The following is a description of a gene set: Any process that activates or increases the frequency, rate or extent of programmed cell death, cell death resulting from activation of endogenous cellular processes. Mouse Gene Set: GOBP_POSITIVE_REGULATION_OF_PROGRAMMED_CELL_DEATH species: Mus musculus, and this is the list of marker genes: Cd40lg, Casp4, Uaca (uveal autoantigen with coiled-coil domains and ankyrin repeats), Fas, Cxcr2, Apbb2, Rbm10, Bmyc, Siah1b, Tnfrsf1a, Htra2, Sirt2, Rrp1b, Tnfrsf10b, Tpd52l1, Bace1, Tcf7l2, Ube2m, Itpr1, Pdcd5 (NCBI Gene Id 98188), Alox12, Nfatc4 (NCBI Gene Id 73181), Nr4a3, Oga, Gadd45g, Tnfsf11, Itm2c, Syk, Nlrc4, Calhm2, Ctsc, Grp, Stk17b (NCBI Gene Id 98267, serine/threonine kinase 17b (apoptosis-inducing)), Fank1, Srpx, Cflar, Ptgis, Camk2b, Camk2d, Pdcd5-ps (NCBI Gene Id 100046198), Cyld, Zfp622, Fbxw7, Prelid1, Bmf, Hrk, P2rx7, Nos3, Mmp9, G0s2, B4galt1, Pin1rt1, Ccn2, Trem1, Endog, Runx3, Adamtsl4, Trpv1, Tex261, Casp7, Zfp346, Nsmaf, Ei24, Gsk3b, Inca1, Ptpa, Jak3 (Janus kinase 3), Septin4, Pak2, Adcy10, Selplg, Fap, Rpl26, Jmy, Fis1, Casp12, Casp8, Fadd, Pawr, Rbm5, Pias4, Rps6-ps4 (NCBI Gene Id 672620), Gper1, Ptgs2, Tsc22d1, Casp9, Bin1, Taf6, Pdcd1, Mmp2, Lpar1, Tfap2b, Trp63, Cdc42, Lats1, Laptm5, D1Pas1, Sod1, Nck1, Neurl1a, Fzd9 (NCBI Gene Id 14371), Bcl2, Tnfsf10, Arg1, Ctla4, Sap18, Map3k11, Itga4, Ptpn1, Ecscr, Bnip3l-ps, Unc13b, H2-M3, Slc27a4, Kcnma1, Plagl2, Map2k4, Ldha, Spink2, Acvr1c, Cdkn2a, Cdk5, Prmt2, Hcar2, Pdcd4, Ahr, Col18a1, Pak3, Grik2, Map3k10, Nos2, Adipoq, Gch1, Il10, Ppp2r1b, Scin, Hmgcr, Ccl12, Grin2a, Inhbb, Rps7, Phb1, Phlda2, Melk, Egr1, Pla2g4a, S100a8, Emilin2, Rapgef2, Bad, Hspa9, Neurod1, Bcl2a1a, Plcg1, Pik3cb, Ctnna1, Nkx3-1, Pomc, Lta, Ndufa13, Slk, Oma1 (NCBI Gene Id 67013), Stpg1, Skil, Ncoa1, Tnfrsf8, Nacc2, Mfn2, Scp2, Ddx3x, Perp, Mtch1 (NCBI Gene Id 98058), Cyct, Foxo3, Ptrh2, Hrg, Itga6, Atf6, Grik5, Apaf1, Ddit3, Fnip1, Casp3, Rps3, Zc3h12a, Foxa1, Epha7, Lcn2, Ptprc, Nox4, Ccl3, Sfpq, Bcap31, Rarb, Arrb1, Agtr2, Dkkl1, Nqo2, Unc5b, Prkci, Cradd, Chek2 (NCBI Gene Id 50883), Ppp1r15a, Folh1, Itga1, Ppargc1a, Bcl2l10, Stat1, Mybl2, Pmaip1, Htatip2, Vdr, Cnr1, Ntrk1, Pdcd2, Aldh1a2, Sox4, Nf1, Cryba1, Gadd45a, Cd160, Tmem164, Psen2, Apc, Tspo, Cers6, Traf2, Socs1, Aimp2, Dnaja3, Wnt10b, Bcl2a1d, Wnt11, Grk2, Sp110, Atg7, Akt1, Trp53bp2, Ing4 (inhibitor of growth family, member 4), Tctn3, Eif5a, Cxcr3, Pml, Mal, Tgfbr1, Ptprf, Ifnb1, Eef1a2, Mybbp1a, E2f3, Trpm7, Olfm1, Sfrp4, Tia1, Tnfrsf22, Gpld1, Pdcd7, Cav1, Cck, Nupr1, Il18, Bcl2a1c, Il19, Ace, Daxx, Jak2, Htra1, Ntrk3 (NCBI Gene Id 414121), Fasl, Tnfsf14, Sap18b, Trim39, Creb1, Muc20 (mucin 20), Muc2, Ing5, Tnfsf15, Nod1, Degs1, Gramd4, Ect2, Tbx20, Tgfb3, Gsn, Capn1, Bdnf, Bbc3, Spdef, Bclaf1, Sphk2, Styxl1, Gsk3a, Ubb, Msx1 (NCBI Gene Id 269644), Steap3, Tradd, Ripk2, Atf2, Prdm11, Clip3, Adrb1, S100a9, Sirt1, Brms1, Diablo, F2r, Bcl2l11, Rarg (retinoic acid receptor, gamma), Spry1, Pparg, Ep300, Nfatc3, Lzts2, Aifm1, Fto, Dffa, Emilin1, Hdac4, Musk, Dlc1, Tgfb2, Tnfsf12, Prr7, Htt, Nox1, Adm, Ido1, Rad9a, Usp27x, Bcl10, Csrnp3, Map3k1, Myb, Parp1, Ppp1ca, Dnm1l, Lrp6, Esr2, Ptpn2, Arrb2, Dhodh, Srpk2, Map2k6, Plekhn1, St8sia2, Clu, Ngfr, Cdk4, Bak1, Rbck1, Ager, Pitx3, Cd47, Vdac1, Nck2, Ncf2, Lep, Tlr3, Msx2, Fam162a, Park7, Nqo1, Ltbr, Rybp, Prkn, Faf1, Aifm2, Ppp2r2b, Tlr4, Bag1, Prkcd, Pou4f1, Fcer2a, Lyn, Rnf122, Txnrd1, Men1, Hmgb1 (NCBI Gene Id 15289), Tle5, Txnip, Phlda3, Mtch2, Utp11, Lgals1, Slc9a1, Siglec1, Foxl2, Cdc34b, Ctrb1, Notch2, Ptn, Zbtb16, Dapk3, Anxa1, Zbp1, Zfas1, Efhc1, Trp73, Rps6ka2, Nfkbid, Dapk1, Bmp4, Fbxo32, Bnip3, Rps6, Fbh1, Grn, Carm1, Moap1, Atf3, Tlr6 (toll-like receptor 6), Rhob, Ankrd1, Dcun1d3, Zmat3, Myc, Agt, Eef1e1, Prnp, Casp14 (NCBI Gene Id 12365), C1qbp, Tfap2a, Isl1, Prf1, Maged1, Inpp5d, Eif2s1, Optn, Ripk1, Bcl2l1, Traf7, Gal, Smad4, Cd274 (NCBI Gene Id 60533), Sfrp2, Rybp-ps, Mapk9, Tigar, Sod2, Aldh1a3, Inhba, Pik3cd, Dapk2, Katnb1, Ano6, Pdcd6, Hif1a, Bmp2, Pla2g1b, Ip6k2, Il6, Rgcc, Nherf1, Sav1, Phlda1, Osm, Il1b, Bcl6, Pla2r1, Ube2z (ubiquitin-conjugating enzyme E2Z), Casp6, Stub1, Arhgef7, Zc3h8, Klrk1, Hyal2, Wt1, Dab2ip, Klf11, Casp2 (NCBI Gene Id 12366), Bcl2l14, Igfbp3, Tomm22, Htra4, Htr2a, Trim35 (NCBI Gene Id 77786), Cdc34, Bok, Grin1, Adrb2, Cd44, Foxp1, Rassf6, C6, Rack1, Tgfb1, Il12a, Ccar1, Spop, Btg1, Irf1, Ccr5, Il24, Adora2a, Atp2a2 (NCBI Gene Id 319250), Ccl5, Nell1, Becn1, Tfpt, Cdkn1a, Cd24a, Cyp1b1, Zfp819, Fam72a, Pea15a, Bard1, Tmc8, Sh3glb1, Slit2, Abl1, Sik1, Pdcd10, Aldh1a1, Plscr1, Tnfrsf1b, Bmp7, Pin1, Gata6, Lats2, Ppid, Cdk19, Cideb, Gzma (granzyme A, NCBI Gene Id 14938), Akr1c18, 4930453N24Rik, Fosl1, Arl6ip5, Atm, Thbs1, Pcsk9, Mef2c, Wwox, Pycard, Ctsh, Dusp1, Apbb1, Il12b, Agrn, Notch1, Atf4, Ifng, Lgals2, Hspd1, Pde5a, Nr4a1, Zswim2, Eif2b5, Sfrp1, Fgfr3 (fibroblast growth factor receptor 3), Mst1, Ddx20, Dedd2, Mllt11, Tnf, Frzb, Cd40, App, Ret, Map3k5, Hip1r, Bax, Capn10, Ltb, Ddx19a, Pip5kl1, Net1, Lck, Tfap4, Bcl2a1b, Ctnnbl1, Gadd45b, Hdac3, Gsdme, Igf2r, Trps1, Flcn, Pxt1, Eif2ak3, Casp1, Rxra, Wdr35, Bcl2l2, Prkdc, Mapk8, Anxa5, Bmpr1b, Mcl1, E2f1, Pdia3, Map2k7, Pidd1, Rapsn (receptor-associated protein of the synapse), Hoxa13, Tgm2, Ripk3, Jun, Bub1, Wnt5a, Itgb1, Trp53, Camk2a, Bid, Pten, Knl1, Sort1 (sortilin 1), Dusp6, Cdk5r1, Rhoa, Usp7, Camk1d, Foxo1, Gsdma3, Ccar2, Cxcl1, Akap12, Egln1, Qrich1, Cd248, Rnps1, Rest, Mtor, Ntsr1, Map3k9, Ppp2r1a, Stk4, Prkra, Map3k20, Id3, Scrib, Ltk, Pdgfrb, Ccn1, Acin1, Psen1, Capn2, Trp53inp1, Lrrk2, Rnf183, Ercc3, Ascl1, Mff, Smpd2, Top2a, Tnfaip8, Smpd1, Src, Hoxa5, S100b, Rassf2, Mycn, Xbp1, Vnn1, Ubd, Il20ra, Dnaja1, Ifit2, Pou4f2 (NCBI Gene Id 18997), Fndc1, Nr3c1, Serinc3, F2rl1 (NCBI Gene Id 14063), Hpgd, Clec7a, Hmox1, Adam10, Irf5, Ctnnb1, Bnip3l, Irf8, Adam17, Syce3, Ctsd, Tmem196, Adam8, Tomm40, Stk3, Tnfrsf12a, Siah1a, Eif2ak2, Unc5c